The following is a description of a gene set: part of: Cytokine Signaling in Immune system This event has been computationally inferred from an event that has been demonstrated in another species.<p>The inference is based on the homology mapping from PANTHER. Briefly, reactions for which all involved PhysicalEntities (in input, output and catalyst) have a mapped orthologue/paralogue (for complexes at least 75% of components must have a mapping) are inferred to the other species. electronically inferred by orthology from the curated human pathway Reactome Pathway: Prolactin receptor signaling studied in species Mus musculus, and this is the list of marker genes: Cul1, Gh